The following is a description of a gene set: studied in species Homo sapiens Genes predicted to be targets of miRBase v22 microRNA hsa-miR-3926 in miRDB v6.0 with MirTarget v4 prediction scores > 80 (high confidence targets). from publication Chen Y, Wang X (PMID 31504780) Human Gene Set: MIR3926, and this is the list of marker genes: PRRC2B, KDM8, SHANK2, CYSTM1, ZNF576, CEP170, JRKL, CHMP2B, STAC2, PAX6, UTRN, RASSF8, KPNA6, ADGRD1, PPP2R5C, ATP6V0E1, CNOT1, LOXL1, NR4A2, MB21D2, CHN1, YIPF4, TENM4, KIAA1549, MUC15, MON2, FLRT3 (fibronectin leucine rich transmembrane protein 3), CEP350, FSBP, PRICKLE2, PLCB1, ELK1, NAA15, HCRTR1, ECHDC1, PCDHB14, ARL6, APBA2 (amyloid beta precursor protein binding family A member 2), NUFIP2, TOM1L2, ABLIM3, CCER1, TDRD1, SP1, KANSL1, SMAD7, ATXN3, FCHSD2, AR, TULP4, ATP6V1D, NR6A1, DHX15, SSBP1, ESYT2 (extended synaptotagmin 2), STK17A, CREB1, DLG1, MED13, UNC93A, RNF146, PTPN11, SLC35F3, RBMX, SCG5, REM2, MMP24, HOMER1, IDS, SCRT2, ANKFY1, SBSPON, TLL2, KLRF1, BRAP, SELENOT, ATP8B2, GNAZ, EFHD2, ELK4, A1CF, CIMIP2B, ADARB1, CSNK1G3, ZNF423, ZNF71, SLC30A5 (solute carrier family 30 member 5), PTX3, RYK, SATB1, KCNG3, FMR1, GHR, LSM12, LVRN, MMP16, RBPJ, RABGAP1, CLIP1, ODAPH, POGZ, TES, SRPK1, CADPS2, VGLL3, C1orf21, KLF6, ALDH1B1, CIT, MOB1B, NIPAL1, ZNF69, DCX, HIF1A, GALR1, PTPRB, ACP3, AGO4, NCMAP, EIF4EBP2, JAM3, MAP3K19, ARHGEF12, CKAP2, PTMA, NMNAT1, C11orf58, HCFC2, TSHZ2, NSRP1, PIAS1, AREL1, CBY1, ZRANB1, AAK1, MAN2B2, RPL15, ARID3B, GPRC5B, NECTIN3, CFAP44, FBLN1, NDUFA2, EEF1A1, VDAC3, PRR15L, POU3F3 (POU class 3 homeobox 3), KRTAP1-3, ZNF318, ATP11A, DEDD2, RTN4IP1, RRAS2, ZNF678, TMEM38B, TTPAL, ASXL3, IGF1, GCC1, CDH11, TNFAIP1, TFRC, POLR1B, BIRC6, MOB3C, PIGA, VPS26A, DDX3Y, NUBPL, FOXG1, RBL1, HSF5, ZDHHC21, TMX1, ZBTB39